Given this list of marker genes IL15, FAP, FOLR3, LOX, LY6D, MMP2, BIRC5, MT2A, PLK1, KIF3C, CDH2, CST6, BUB1 (NCBI Gene Id 699), CUL3, PPP3R1, IGFBP7, FN1, BRCA1, here is a description of the gene set: species: Homo sapiens Human Gene Set: KARAKAS_TGFB1_SIGNALING from publication Karakas B, Weeraratna A, Abukhdeir A, Blair BG, Konishi H, Arena S, Becker K, Wood W 3rd, Argani P, De Marzo AM, Bachman KE, Park BH (PMID 16619041) Transforming growth factor-beta type 1 (TGF-beta) has been implicated as both a tumor suppressor and a tumor promoter in many solid epithelial cancers. We have previously demonstrated that the cyclin dependent kinase (CDK) inhibitor p21 acts as a molecular switch in determining a growth inhibitory versus growth proliferative response to TGF-beta in the spontaneously immortalized human mammary epithelial cell line MCF-10A. We now demonstrate that this proliferative effect of TGF-beta is mediated through the proinflammatory cytokine, interleukin-1alpha (IL-1alpha). Using gene expression array analysis, we identified IL-1alpha as a cytokine specifically upregulated only in cells lacking p21 and only upon TGF-beta stimulation. Cell proliferation assays verified that recombinant IL-1alpha was capable of inducing a growth proliferative response in p21 null MCF-10A cells, while neutralizing antibodies against IL-1alpha prevented the growth proliferative effects of TGF-beta. Mechanistically, both the CDK and proliferating cell nuclear antigen (PCNA) inhibitory functions of p21 were responsible for preventing TGF-beta induced cell proliferation, but only PCNA inhibition by p21 regulated IL-1alpha gene expression. These studies demonstrate a novel role for IL-1alpha in mediating a proliferative response to TGF-beta signaling, and suggest that therapies directed against IL-1alpha could abate the growth proliferative effects of TGF-beta without compromising its tumor suppressive function. Genes up-regulated by TGFB1 in MCF10A cells (breast cancer): both wild-type and those lacking p21.